The following is a description of a gene set: studied in species Homo sapiens Human Gene Set: GOBP_ATTACHMENT_OF_MITOTIC_SPINDLE_MICROTUBULES_TO_KINETOCHORE The cellular process in which spindle microtubules become physically associated with the proteins making up the kinetochore complex in mitosis., and this is the list of marker genes: NUF2, CDCA8, KAT2B, INCENP, NDC80, CDK1, SKA2, BIRC5, BECN1, BOD1, SKA1, KAT5, CENPE, CENPC, AURKB, MIS12, SKA3, RMDN1, CDT1, CHAMP1, KIF2C, SEH1L, MAD1L1, SIRT1, MAPRE1, HNRNPU